Given this list of marker genes DNAJB7 (DnaJ heat shock protein family (Hsp40) member B7), KCNG4, ST6GALNAC5, INTS11, AWAT1, BTG2-DT, FDXR, ANKRD36, DHX57 (DExH-box helicase 57), ZFP91, CDAN1, OGFRP1, CHRNG, ATAD3B, IGLV3-19, DLEC1, ERICH5, FAM151A, FAM43B, FAM230C, ISX (intestine specific homeobox), SLFN13, RNF151, ANKFN1, SPATA31F1, KRTAP4-8, IGF2BP2-AS1, P2RX6, ANKRD45, GMEB1, TNF, SDCCAG8, MDC1, PTPN22, TMOD2, LINC03122 (long intergenic non-protein coding RNA 3122), CARD18, ALPL, RAG1, EDNRB-AS1, TBX1, BCAM, TIMD4, CCDC144NL-AS1, IL22, TARS1, KCNQ3, FICD, OBP2B, TMPRSS2 (transmembrane serine protease 2), ARRDC1-AS1, AK4, SGMS1, KLHDC7A, RIC3, AKAP9, INPP4A, ATL2, ENSG00000255537, TMEM72, LINC02709, GATA5, H4C3, PLEKHG6 (pleckstrin homology and RhoGEF domain containing G6), BORCS5, NTRK2, ROPN1, KIAA0087, DKK4, RBP3, CDR1 (cerebellar degeneration related 1), EVX1, SAMD15, MPHOSPH9, VPS11, KRTAP8-1, C1GALT1C1L, SERPINB11, BPTF, CT83, TOM1L1, YJU2B, LINC00924, ZNF781, KCNG2, CLEC3B, MYO1D, RTP4, EOLA2-DT, LEP, VWA1, NBEAP1, RNF152, FGF1, H19, LINC00184, RBM25, GGACT, SGO2, LINC00857, ZNF436, ANGPTL1, LDLRAD4-AS1, VSTM2A-OT1, H1-3, HECTD1, IFT27, FAM107A, TONSL, CAPN10 (calpain 10), LINC00314, PMS2P4, RTP1, FAM215A, UTP11, NLE1, IL36B, SMIM31, SELE, CLEC4F, CENATAC (NCBI Gene Id 338657), CLDN1, NHERF2, LINC00943, PIK3CD-AS1, TIGIT, DCAF4L1, EREG, BASP1-AS1, RARRES2, ZNF28, IL6, TAAR5, C7orf50, GARIN2, IFNA8, ATP8A2, IRGM, TFF2, ENTREP2, H2BC8 (NCBI Gene Id 8339), EPCIP, NECAP2, NUP210P1, PACRG, HNRNPA2B1, LINC00645, LRFN1, PDILT, DHX32, DDX53, ZNF385D, SLC25A13, NACAD, LOXL1, H2BW2, IGHV7-81, PROCA1, SLC4A8, MIPOL1, ZNF233, H4C2, CACTIN, ZNF17, TPD52L3, TEAD1, PCGF6, H3C11, CFAP210 (cilia and flagella associated protein 210), TSACC, TLE2, SLC38A4-AS1, CARMIL2, CCL20, A1BG-AS1, DEFB124, CACNA1G, ZNF461, NEK11, FARP1, ADSS2, SLC11A2, LINC01310, SOCS2-AS1, GPSM1, NEBL-AS1, TRUB2, ZNF197, DPYSL3, MAP2K4, here is a description of the gene set: studied in species Homo sapiens from publication Nakaya HI, Wrammert J, Lee EK, Racioppi L, Marie-Kunze S, Haining WN, Means AR, Kasturi SP, Khan N, Li GM, McCausland M, Kanchan V, Kokko KE, Li S, Elbein R, Mehta AK, Aderem A, Subbarao K, Ahmed R, Pulendran B (PMID 21743478) Human Gene Set: GSE29615_CTRL_VS_DAY7_LAIV_FLU_VACCINE_PBMC_DN Genes down-regulated in comparison of peripheral blood mononuclear cells (PBMC) from LAIV influenza vaccine pre-vaccination versus those at day 7 post-vaccination. Systems vaccinology has emerged as an interdisciplinary field that combines systems wide measurements and network and predictive modeling applied to vaccinology. Here we used the systems vaccinology approach to study the molecular mechanisms underlying the innate responses to the trivalent inactivated influenza (TIV) and live attenuated influenza (LAIV) vaccination in humans, and to identify early gene signatures that predict the magnitude of the antibody responses to influenza vaccination.